Given this list of marker genes NOTCH1, BMP5, SOS1, BMP7, FLRT3, TBX20, WNT5A, DLL4, here is a description of the gene set: species: Homo sapiens The process in which the anatomical structure of the pericardium is generated and organized. Human Gene Set: GOBP_PERICARDIUM_MORPHOGENESIS